The following is a description of a gene set: part of: Transcriptional regulation by RUNX3 Reactome Pathway: Regulation of RUNX3 expression and activity RUNX3, like other RUNX family members, is transcribed from two promoters - the proximal P2 promoter and the distal P1 promoter. The P2 promoter is positioned within a large CpG island that is frequently methylated in solid tumors, resulting in epigenetic inactivation of the RUNX3 gene. RUNX3 transcription is affected by SMAD4 levels. RUNX3 may directly upregulate its own transcription through a positive feedback loop. Under hypoxic conditions, RUNX3 transcription is downregulated. Hypoxic silencing of RUNX3 involves hypoxia-induced upregulation of the histone methyltransferase G9a and histone deacetylase HDAC1, which leads to increased dimethylation of histone H3 at lysine residue K9 (K10 when taking into account the initiator methionine) and reduced acetylation of histone H3 at the RUNX3 promoter.<br>RUNX3 protein levels are inversely related to the levels of microRNA miR-130b. Based on in silico analysis, RUNX3 is predicted to be the target of miR-130b, but binding assays and 3'UTR reporter assays have not been done to confirm this.<br>Similar to RUNX1 and RUNX2, RUNX3 forms a transcriptionally active heterodimer with CBFB (CBF-beta). RUNX3 activity can be regulated by changes in RUNX3 localization. SRC protein tyrosine kinase phosphorylates RUNX3 on multiple tyrosine residues, inhibiting its translocation from the cytosol to the nucleus and thus inhibiting RUNX3-mediated transcription. Subcellular localization of RUNX3 may be affected by PIM1-mediated phosphorylation.<br>The P1 and P2 promoters regulate RUNX3 transcription in a cell-type/differentiation dependent manner, giving rise to the p44 and p46 isoforms of RUNX3, respectively. Several splicing isoforms have also been reported. One example is the generation of a 33 kDa protein isoform (p33) by alternative splicing. The RUNX3 p33 isoform lacks the Runt domain and is unable to transactivate the regulatory regions of integrin genes. The p33 isoform is induced during maturation of monocyte-derived dendritic cells (MDDC), leading to reduced expression of genes involved in inflammatory responses, such as IL8 (interleukin-8).<br>E3 ubiquitin ligases MDM2, SMURF1 and SMURF2 are implicated in RUNX3 polyubiquitination and degradation. species: Homo sapiens, and this is the list of marker genes: PSMD12, PSMD14 (proteasome 26S subunit, non-ATPase 14), PSMC5, PSMA1, MDM2, CBFB, PSMB1, PSMA2, PSMC1 (proteasome 26S subunit, ATPase 1), PSMC6, PSMD6, PSMD13, RUNX3, SEM1, PSMD1, ADRM1, PSMA7 (proteasome 20S subunit alpha 7), PSMB6, TGFB1, PSMB3, PSMA5, PSMB2, PSMB5, UBA52, EP300, PSMC3, CDKN2A, PSMD8, PSMD2, PSMD3, PSMA3, PSMB4, PSMD7, PSMA4, SRC, SMURF2, PSMC4, UBC, PSMD11, RPS27A, SMURF1, PSMC2, PSMA6, UBB, PSMB7